The following is a description of a gene set: Human Gene Set: HP_MALE_PSEUDOHERMAPHRODITISM Male pseudohermaphroditism Hermaphroditism refers to a discrepancy between the morphology of the gonads and that of the external genitalia. In male pseudohermaphroditism, the genotype is male (XY) and the external genitalia are imcompletely virilized, ambiguous, or complete female. If gonads are present, they are testes. studied in species Homo sapiens, and this is the list of marker genes: TMEM237, AKR1C4, WT1, CC2D2A, RPGRIP1, CYB5A, COX7B, TCTN1, AMH (NCBI Gene Id 268), CEP290, TMEM107, HSD3B2, B9D1, SOX9, TCTN3, NR0B1, DMRT1, MAP3K1, SRY, HHAT, RPGRIP1L, HSD17B3, CYP17A1, DHH, CSPP1, AR, TCTN2, CYP11A1, HCCS, TMEM67, NR5A1, AMHR2, B9D2, CBX2, TMEM216, TMEM231, AKR1C2, TXNDC15, NDUFB11, ATRX, MKS1 (NCBI Gene Id 54903), DHX37